The following is a description of a gene set: Binding to a tetratricopeptide repeat (TPR) domain of a protein, the consensus sequence of which is defined by a pattern of small and large hydrophobic amino acids and a structure composed of helices. studied in species Mus musculus Mouse Gene Set: GOMF_TPR_DOMAIN_BINDING, and this is the list of marker genes: Trak1, Rab8b, Hsp90ab1, Stub1, Trak2, Hsp90aa1, Pde2a, Srp72